Given this list of marker genes Spns2, Cd200 (NCBI Gene Id 17470), Ccl26, Cd99l2 (CD99 antigen-like 2), Ccl5, Aif1, Myo1g, Abl1, Ascl2, Med23, F11r, Itgb3, Cxcl13, Spn, Ccl2, Cxcr3, Ccr7, Wnt5a, Adam8, Crkl, Ripor2, App, Tmem102, Cxcl10, Crk, Cxcl16, Tnfsf4, Gpr183, Adam10, Gpr15lg, Tnfsf14, Ecm1, Xcl1, Icam1, Cxcl11, Fut7, Lgals9 (lectin, galactose binding, soluble 9), Selenok, Abl2, Ccr6, Rhoa, Cd200r1, Gnai1 (NCBI Gene Id 14677), Tnfrsf14, S1pr1, Fadd, Msn, Adam17, Itga4, Cxcl12, Itgb7, Aire, Cd69, Stk39, Oxsr1, Il27ra, Wnk1, Dock8, Ccl20, P4hb, Slc12a2, Ripk3, Coro1a, Itgal, Plec, Apod, Ccl3, Gpr15, Ccr2, Pycard, Lrch1, Ccl21a (C-C motif chemokine ligand 21 (serine)), here is a description of the gene set: Mouse Gene Set: GOBP_T_CELL_MIGRATION The movement of a T cell within or between different tissues and organs of the body. species: Mus musculus